Given this list of marker genes Nudt21, Cpsf3, Cpsf6, Tut1, Cpsf7, Papola, Zcchc8, Ssu72, Cstf3, here is a description of the gene set: Mouse Gene Set: GOBP_CO_TRANSCRIPTIONAL_RNA_3_END_PROCESSING_CLEAVAGE_AND_POLYADENYLATION_PATHWAY species: Mus musculus Any process involved in transcription termination-coupled 3' processing of RNA polymerase II RNA transcripts by 3' end cleavage and addition of a poly(A) tail.